Given this list of marker genes RARS2 (NCBI Gene Id 91066), GLB1, HSPD1, GPRC5B, ABCA12 (ATP binding cassette subfamily A member 12), CHMP2B, SOX10, SLC19A3, ARX, MTPAP, CSF1R, REEP1, ATXN2, OPA1, GFM2, GSS, IBA57, THOC2, CFAP410, SLC4A10, ZFYVE26, PRDM13, CYP2U1, MRPS22, GBA1, CPT1C, MRM2, GTPBP2, BCL11B, SOD1, NEU1, AFF3, CCT5, LIPT2 (lipoyl(octanoyl) transferase 2), SIGMAR1, TREX1, SELENOI, REPS1, ALG9, TBCD, FLNA, SCN2A, ATP5MC3, UCHL1, COA8, SMC1A, EXOC2, IFIH1, NSRP1, DSTYK, FAR1, DDHD1, PON3, POLR1A (NCBI Gene Id 90784), LIAS, CLIC2, LMNB1 (lamin B1), CLN8 (NCBI Gene Id 619435), TPK1, SPG7, OPTN, NUS1, TUBA1A, LMX1B, GM2A, DNM1, RERE, KCNJ6, SRPX2, TEFM, PIGA, NEFH (NCBI Gene Id 4744), TBCE, MAN2B1, SLC18A2, C19orf12, HMBS, HUWE1, ATP5MK, DCTN1, SEC31A, REEP2, SETX, MATR3, SEPSECS, GFAP, PEX3, GUF1, VPS37A, DEGS1, RARS1, PAFAH1B1, SPG21, TMEM63C, KIF5A, TMX2, VAPB, FARS2, MTRFR, SOX2, H4C5, AP4B1, SATB1, PI4KA, PNPLA6, AUH, LYST, CLTC, ERCC8, PFN1, KIDINS220 (NCBI Gene Id 57498), PCDH12, GBA2, SCN3A, BSCL2, HIKESHI, YIF1B, ATL1, AFG2B, PNP, ACTL6B, TSEN15, PPFIBP1, KLC2, L1CAM, L2HGDH, UBAP1, ELOVL4, WWOX, CACNA1D, KY, TRAPPC4, SDHD, AASS, PRDM8, KIF1A, PDHX (NCBI Gene Id 8050), WDR62, RNASEH2B, MTHFR, UNC13A, OPA3, HSD17B10, CDC40, NEXMIF, ACBD6, ARSI, GJC2, DTYMK, ADD3, TCEAL1, HMGCL, ADAR, B4GALNT1, PPARGC1A, DNM1L, RNASEH2A, TTI1, CASK, PRNP, MECP2, FBLN1, CNPY3, ERLIN2, POLG, ASNS, TANGO2, DPH5, WDR45B, NFU1, DARS1, BTD, AMFR, NUP62, HSD17B4, TOE1, DNAJC19, NAXD, ABHD16A, TACO1, CCDC88C, AIMP1, ERCC4, CYP27A1, SLC35A2, APOE (apolipoprotein E), SPTBN1, ATP6AP2, ACTB, PSAT1, VWA3B (NCBI Gene Id 200403), ATP5F1A, RAB3GAP1, SLC16A2, USP8, DENND5A, PSEN1, LYRM7, TTR, PPIL1, TUBB3, FUS (FUS RNA binding protein), AARS1, WDR73, PON2, CTNNB1, GLT8D1, SHMT2, ZNF668, KPNA3, KDM5C, PET100, PRRT2, FCSK, ELOVL1, ERCC6, AP4S1, NDUFA13, SPTLC1, MOCS1, GAMT, VPS41, PLP1 (proteolipid protein 1), ATXN10, RAP1GDS1, MRAP, SLC30A10, SPTAN1, TAF1, GLRX5, WASHC5, CAMK2B, ATP6V1A, VPS53, EDNRB, TMTC3, CYB5A, CAPN1 (calpain 1), TARDBP, MOCS2, MICOS13, COL4A2, RFXANK, POLR3GL, PGAP1, HACE1, RANBP2 (RAN binding protein 2), PQBP1, KCNC2, FA2H, COG2, CCNF, APC2, GRIN1 (NCBI Gene Id 2902), DDHD2, KIF2A, LIPT1, NDUFA4, EXOSC8, KANK1, EARS2, COX15, FIG4, AIFM1, MED13L, EIF4A2, GOT2, HEPACAM, GBE1, TECPR2, LONP1, CHCHD10, RNU7-1, SYNE1, SDHB, CYB5R3, NALCN, RAB18, SLC25A15, GJA1, ERLIN1, ALDH3A2, ATPAF2, ZFR, ATP13A2, SPAST, CLCN4, LSM11, BICD2, MT-ATP6, CYP7B1, STAMBP, MRE11, ESAM, WARS2, EIF2S3, TAF15, LAMB1, SNAPC4, SPG11 (SPG11 vesicle trafficking associated, spatacsin), FUCA1 (alpha-L-fucosidase 1), NDE1, PEX16, AP4E1, CACNA1E, ARG1, STXBP1, DAO, PSAP (NCBI Gene Id 83009), AFG3L2, ENTPD1, INPP5K, DYNC1H1, SOX4 (NCBI Gene Id 6659), SHQ1, ATRX (ATRX chromatin remodeler), ATP5F1D, TBK1, NIPA1, MARS1, AP5Z1, GLYCTK, DYM, ODC1, SYNJ1, TTC19, SDHAF1, ELP2, MCOLN1, PRPH, RNASEH2C, ATP6V0A1, NTRK2, TRAPPC12, PSMC1, HPDL, TRMT10A, TREM2, VAMP1 (NCBI Gene Id 6843), EIF2AK1, KIF5C, GPT2, GRIA4, ATN1, SPART, MT-ATP8, PRUNE1, AHDC1, CAMLG, OSTM1, RNU4-2, GALC, ASCC3, TFG, SIX6, COQ4, CACNA1C, UBE4A, FLRT1, NDUFAF4, ARL6IP1 (ADP ribosylation factor like GTPase 6 interacting protein 1), SATB2, AMPD2, MINPP1, MTFMT, SQSTM1, WDR45, ANXA11, RNF220, GLE1, CNTNAP2, UBQLN2, RNF170, RAB3GAP2, INTS8 (integrator complex subunit 8), SLC33A1, PHGDH (phosphoglycerate dehydrogenase), COQ5 (NCBI Gene Id 84274), NAA10, SLC2A1, KCNQ2, TUBG1, UNC80, ALS2, RTN2, KARS1, GATAD2B, SPTSSA (serine palmitoyltransferase small subunit A), AP1S2, TNR, TMEM222, ANG, ARSA, SAMHD1, IDUA, ADGRG1, PHACTR1, SACS, PPP1R15B, PLA2G6, ACP5, WDR48, NT5C2, STUB1, AP4M1, ATP5F1E, MFSD2A, OTUD6B, COASY, ALDH18A1, GAN, CTNNA2, GCDH, NUP54 (NCBI Gene Id 53371), SDHA, TSPOAP1, ACER3 (alkaline ceramidase 3), TBC1D20, COLGALT1, ALG3, VCP (valosin containing protein), NEK1, ERCC1, SLC1A4, HNRNPA1, NDUFAF5, PRPS1, ERBB4, PON1, BCOR, PAX3, CNP, MAG, ABCD1, FBXO7, HECTD4, GSX2, ANKLE2, here is a description of the gene set: Appendicular spasticity studied in species Homo sapiens A type of spasticity that affects one or more limbs (arms or legs). Human Gene Set: HP_APPENDICULAR_SPASTICITY